The following is a description of a gene set: Human Gene Set: DURANTE_ADULT_OLFACTORY_NEUROEPITHELIUM_RESPIRATORY_HORIZONTAL_BASAL_CELLS species: Homo sapiens from publication Durante MA, Kurtenbach S, Sargi ZB, Harbour JW, Choi R, Kurtenbach S, Goss GM, Matsunami H, Goldstein BJ (PMID 32066986), and this is the list of marker genes: TACSTD2, PERP, AQP3, SLC25A5, ANXA2, FXYD3, NTS, ATP1B3, PRDX1, ALDH3A1, CALML3, KRT19, KRT6A, S100A2, PHLDA2, CLDN4, PKM, S100A16, MT1X, SERPINB4, SFN, SERPINB5, KRT23, KRT5, KLF5, KRT18, CD9, LYPD3, KRT8, ELF3, ANXA1, HSPB1, S100A11